Given this list of marker genes Tubb4b, Cetn2, Tubgcp4, Ppp2r1a, Tuba4a, Cep57, Tubg1, Csnk1d, Akap9, Alms1, Cep250, Tuba3b, Cep152 (centrosomal protein 152), Tubb1, Cep192, Cep43, Ckap5, Tubg2, Sfi1, Cep76, Pafah1b1, Tubb5, Nedd1, Csnk1e, Tubb2a, Cep78, Tubgcp3, Tuba1c, Haus3, Tuba3a, Cdk5rap2, Tubb3, Prkaca, Dctn2, Hsp90aa1, Tubgcp6, Dync1i2 (dynein cytoplasmic 1 intermediate chain 2), Mapre1, Haus2, Actr1a, Tubgcp5, Cep70, Haus6, Cep164, Tubgcp2, Tubb6, Ssna1, Haus8, Ofd1, Dctn3, Cep41, Odf2, Ywhae, Cep72, Haus1, Cdk1, Numa1, Tubb2b, Dync1h1, Ninl, Haus4, Haus7, Cep131, Plk1, Tubb4a, Clasp1, Cenpj, Sdccag8, Tuba1b, Haus5, Dynll1, Tubal3, Plk4, Ywhag, Nde1, Tuba8, Pcm1, Tuba1a, Nme7, Cep290, Mzt2, Mzt1, Cep63, Nek2, Ccp110, Dctn1, Cep135, here is a description of the gene set: Recruitment of NuMA to mitotic centrosomes species: Mus musculus Mouse Gene Set: REACTOME_RECRUITMENT_OF_NUMA_TO_MITOTIC_CENTROSOMES